The following is a description of a gene set: Human Gene Set: NIKOLSKY_BREAST_CANCER_19P13_AMPLICON A single cancer cell contains large numbers of genetic alterations that in combination create the malignant phenotype. However, whether amplified and mutated genes form functional and physical interaction networks that could explain the selection for cells with combined alterations is unknown. To investigate this issue, we characterized copy number alterations in 191 breast tumors using dense single nucleotide polymorphism arrays and identified genes with copy number gain organized into 30 amplicons. Amplicons were distributed unequally throughout the genome. Each amplicon had distinct enrichment pattern in pathways, networks, and molecular functions, but genes within individual amplicons did not form coherent functional units. Genes in amplicons included all major tumorigenic pathways and were highly enriched in breast cancer-causative genes. In contrast, genes with somatic mutations in breast cancer were distributed randomly over the genome, did not represent a functionally cohesive gene set, and were relatively less enriched in breast cancer marker genes. Mutated and gained genes did not show statistically significant overlap but were highly synergistic in populating key tumorigenic pathways including transforming growth factor beta, WNT, fibroblast growth factor, and PIP3 signaling. In general, mutated genes were more frequently upstream of gained genes in transcription regulation signaling than vice versa, suggesting that mutated genes are mainly regulators, whereas gained genes are mostly regulated. ESR1 was the major transcription factor regulating amplified but not mutated genes. Our results support the hypothesis that multiple genetic events, including copy number gains and somatic mutations, are necessary for establishing the malignant cell phenotype. from publication Nikolsky Y, Sviridov E, Yao J, Dosymbekov D, Ustyansky V, Kaznacheev V, Dezso Z, Mulvey L, Macconaill LE, Winckler W, Serebryiskaya T, Nikolskaya T, Polyak K (PMID 19010930) studied in species Homo sapiens Genes within amplicon 19p13 identified in a copy number alterations study of 191 breast tumor samples., and this is the list of marker genes: NR2F6, USE1, OCEL1, USHBP1, MYO9B